The following is a description of a gene set: from publication Whitfield ML, Sherlock G, Saldanha AJ, Murray JI, Ball CA, Alexander KE, Matese JC, Perou CM, Hurt MM, Brown PO, Botstein D (PMID 12058064) studied in species Homo sapiens The genome-wide program of gene expression during the cell division cycle in a human cancer cell line (HeLa) was characterized using cDNA microarrays. Transcripts of >genes showed periodic variation during the cell cycle. Hierarchical clustering of the expression patterns revealed coexpressed groups of previously well-characterized genes involved in essential cell cycle processes such as DNA replication, chromosome segregation, and cell adhesion along with genes of uncharacterized function. Most of the genes whose expression had previously been reported to correlate with the proliferative state of tumors were found herein also to be periodically expressed during the HeLa cell cycle. However, some of the genes periodically expressed in the HeLa cell cycle do not have a consistent correlation with tumor proliferation. Cell cycle-regulated transcripts of genes involved in fundamental processes such as DNA replication and chromosome segregation seem to be more highly expressed in proliferative tumors simply because they contain more cycling cells. The data in this report provide a comprehensive catalog of cell cycle regulated genes that can serve as a starting point for functional discovery. The full dataset is available at http://genome-www.stanford.edu/Human-CellCycle/HeLa/. Human Gene Set: WHITFIELD_CELL_CYCLE_G2 Genes periodically expressed in synchronized HeLa cells (cervical carcinoma), with peak during the G2 phase of cell cycle., and this is the list of marker genes: KPNA2, CFAP90, CKAP2, CDCA2, HJURP, KATNA1, CFD, DET1 (NCBI Gene Id 55070), CENPL, KBTBD2, KATNBL1, ARHGAP19, TFAP2A, MEPCE, FAM110A, CFLAR, NMB, AP3D1, NCOA5, TUBD1, BCLAF1, H2AX, RNF141, DCAF7, ZNF587, FAM72B, FANCD2, POLQ, NUSAP1, H2AC25, CDK1, NCAPH, STIL (STIL centriolar assembly protein), CDKN1B, CDKN2C, HP1BP3, BORA, KIF23, PSRC1, G2E3, LBR (lamin B receptor), ANLN, DNAJB1, PKNOX1, MALAT1, ADGRG6, TUBB2A, VTA1, RIDA, RCCD1, TIMP1, CKAP2L, RANGAP1 (NCBI Gene Id 6381), NFIC, CDC25C (NCBI Gene Id 995), CYTH2, TTC38, KIF5B, TMPO, SGCD, PIF1, NNMT, CEP350, NUCKS1, FADD, TUBB4B (NCBI Gene Id 10383), CCNA2, IFNAR1, PCED1A, NLRP2, LIX1L, NR3C1, LMNB1, CASP3, ATL2, CDR2, MND1, TUBB, TEDC1, RHNO1, MAD2L1, TRIM69, MIS18BP1, ENTPD5 (ectonucleoside triphosphate diphosphohydrolase 5 (inactive)), CDCA8, BUB3, RGS3, KIF11, WDR62, UBE2C, CHEK2, GABPB1, ZNHIT2, CYB5R2, LTBP3, FAN1, RDH11, NCAPD3, TRMT2A, SORL1, ARHGAP11B, KIF22, JPT1, KDM4A, SAP30, MTCL1, UNC5CL, GAS1, FZR1, TUBA4A, TRIM59, TRAIP, WSB1, STK17B, UBXN11, HAUS8, NDC80, STAT5B, PPP1R2, NEIL3, SV2B, CDCA3, TUBA1A, BTNL9, KLF6, DHX8, HINT3, CXCL14, SMC4, TOP2A, CBX5, EBI3, NIPBL, TUBA3C, TMEM132A, CIP2A, CDKL5, UACA, CCNF, CDC16, HCP5, HSPA2, SKA3, MET, STAT1, C2orf69, TYSND1, AURKB, TNPO2, HMGB2, CCN4, TTF2, MUC1, NUMA1, ASXL1, ARMC1, VPS25, GAS2L3, FAM83D, KIFC1, MELK, ESPL1, MGAT2, ALKBH1, HIPK2, MID1, ARHGEF39, BRD8